Given this list of marker genes ZFAND4, NXPE3, CNNM1, ATP11C, CAMK1D, ARIH1, C2CD6, HIPK1, TOX3, ARMCX3, LANCL2, CD27, GNAI1, CA8, PTPMT1, HS3ST3B1, TCF24, KANK1, MTRFR, RNMT, UGT8, SGCD, ZNF347, SLC26A3, COQ10A, RNF169, EREG, BET1, AHCY, FMOD, CAPZA2, TMEM38B, PELO, NFIB, PDLIM2, PPARGC1A, AMMECR1, BORA, ZNF90, EML1, NCBP1, USP9Y, PCLO, ATF1, ENPP2, MAN1A1, MESD, ELOVL1, KAT6B, ZBED1, ZNF28, JAZF1, TTLL11, MNT, DEK, ZNF716, PIWIL3, ZNF626, ATP6V1C2, ZBTB10, SELENOI, STK4, C11orf86, C5orf24, XKR4, CNTN1, SPRY4, ATP11B, CACYBP, SLC4A7, IQCA1, PCNP, LFNG, NWD1, BROX, MTMR3, WDR33, ST6GAL1, C15orf40, SP2, S100PBP, EDRF1, GDE1, KITLG, ACTRT3, MSL2, BECN1, OXR1, CDK6, KIDINS220, CWC25, IRF2BP2, TM7SF3, RFX7, TSKU, PARD3B, EPHB1, ZC3H12D, LBH, SAMD8, TGFBI, ENOX1, PITPNM3, HDGFL3, FAM135A, KLHL14, here is a description of the gene set: Genes predicted to be targets of miRBase v22 microRNA hsa-miR-6773-3p in miRDB v6.0 with MirTarget v4 prediction scores > 80 (high confidence targets). species: Homo sapiens from publication Chen Y, Wang X (PMID 31504780) Human Gene Set: MIR6773_3P